Given this list of marker genes ANXA4, SSH1, GNA12, GBP4, DDC, CNNM3, NDRG1, DUSP4, IFT80, WBP2, ZNF862, SH3BP5L, THOC7, DRC3, LRIG1, TP53I11, ZC3H12A, MPZL2, TNNT2, TIAM1, ASB7, CACNA1A, ADGRE5, TBC1D10A, CLIP3, VAMP5, BMPR2, TCEAL8, PARD6B, GCAT, EFCAB2, HSD17B11, ARHGAP20, GIMAP7, CC2D2A, TTC28 (tetratricopeptide repeat domain 28), FBXO30, FAM210B, KLRG1 (NCBI Gene Id 10219, killer cell lectin like receptor G1), RIMS3, PGPEP1L, MRTFB, CAPSL, GPAT2, SLC16A3, KLF9, NFKB1, ALDH18A1, DBP, TAMALIN (trafficking regulator and scaffold protein tamalin), MCF2L, WIPI2, HIP1R, CFAP410, CERK, TOM1L2, GPHN, GTDC1, JDP2, TTC39B, GFOD1, TSPAN32, UBXN6, GM2A, OMA1, ILVBL, BNIP5, LHFPL6, COLQ, CPD, IGSF9, PMS1, TEX15, PLCL1 (NCBI Gene Id 5334), ENO2, FRMD4B, SKI, HLA-G, GBP6, ZDHHC2, C6orf89, CA8, GK5, PRMT2, RALGPS1, CD99L2, ARL5A, SNX16, PRG4, RBPJ, SMOX, NINJ1, NCOA3, NTN1, TNFRSF1B, FBXO31 (NCBI Gene Id 84204), MYO1E, TGIF1, SLC35D1, NDRG4, MYO1C, PTPRS, PRR13, KIF3B, PTPN9 (NCBI Gene Id 5780), CAST, MBNL3, IL10RB, BAHD1, LNX2, RTL5, COMTD1, PHTF2, PMEPA1, FCRL1, SELP, DNAH7, RHOF, GNA15, CMTM7, ZCCHC18, UNC119, TEX35, STAT4, PFKFB1, ZNF839 (zinc finger protein 839), ZSCAN12, PLA2G4F, STX11, CCN4, GCH1, CYTH3, NOD1, BHLHE40, HK2, HEMK1, NAF1, TBC1D30, ATXN1, FOXO3, WNT3, DIABLO, ENO3, LCA5, CNDP2, PHLPP1, NFKBIB, GREB1, ITGA6, RRAGD, LIPE, DAG1, DCAF8, CD86, TDRD7, STARD10, PPP1R21, PTGER4, NRN1, CREBL2, SLC12A4, HIPK2, CISH, STAT5B, ABCC1, SNRNP35, ABTB1, FHIP1B, PLCB3, PURG, ANKRD55, RYR2, NR4A3, FAM241A, EEF2K, AIDA, ATOSB, ENTREP3, APIP (NCBI Gene Id 51074), GSAP, ST3GAL2 (ST3 beta-galactoside alpha-2,3-sialyltransferase 2), HMGN3, HLA-DOB, LAMC1, CRIM1, TMTC4, ABHD6, NSMAF, NOTCH2, CSRP2, RNF19B, PLSCR1, ZNF219, PRICKLE1, DEDD2, INPP5F, GALM, BBS2, TNFRSF25, PHC1, here is a description of the gene set: Human Gene Set: GSE40277_EOS_AND_LEF1_TRANSDUCED_VS_GATA1_AND_SATB1_TRANSDUCED_CD4_TCELL_UP studied in species Homo sapiens from publication Fu W, Ergun A, Lu T, Hill JA, Haxhinasto S, Fassett MS, Gazit R, Adoro S, Glimcher L, Chan S, Kastner P, Rossi D, Collins JJ, Mathis D, Benoist C (PMID 22961053) The transcription factor FoxP3 partakes dominantly in the specification and function of FoxP3+ CD4+ T regulatory cells (Tregs), but is neither strictly necessary nor sufficient to determine the characteristic Treg transcriptional signature. Computational network inference and experimental testing assessed the contribution of several other transcription factors (TFs). Enforced expression of Helios or Xbp1 elicited specific signatures, but Eos, Irf4, Satb1, Lef1 and Gata1 elicited exactly the same outcome, synergizing with FoxP3 to activate most of the Treg signature, including key TFs, and enhancing FoxP3 occupancy at its genomic targets. Conversely, the Treg signature was robust to inactivation of any single cofactor. A redundant genetic switch thus locks-in the Treg phenotype, a model which accounts for several aspects of Treg physiology, differentiation and stability. Genes up-regulated in CD4 T conv over-expressing: IKZF4 and LEF1 versus GATA1 and SATB1 versus GATA1 and SATB1.